The following is a description of a gene set: species: Mus musculus Mouse Gene Set: GOBP_RESPONSE_TO_AMINE Any process that results in a change in state or activity of a cell or an organism (in terms of movement, secretion, enzyme production, gene expression, etc.) as a result of an amine stimulus. An amine is a compound formally derived from ammonia by replacing one, two or three hydrogen atoms by hydrocarbyl groups., and this is the list of marker genes: Gnal, Myd88, Ppp1r9b, Nqo1, Drd1, Asic1, Slc1a1, Nr4a2, Ppp3ca, Pitx3, Itga2, Grin1 (glutamate receptor, ionotropic, NMDA1 (zeta 1)), Grin2a, Rgs9, Edn1, Rgs2, Ednra, Ppp1r1b, Gria1, Adra1b, Atp1a3, Cxcl2, Drd3, Jak2, Slc18a2, Adora2a, Drd5, Cps1, Gldc, Comt, Hnmt, Hprt1, Rps6kb1, Rgs10, Drd2, Cad, Trdmt1, Pde1b, Th, Oxtr, Adamts13, Drd4, Kcnc2, Cdk1, Rrm2b, Fosb (FBJ osteosarcoma oncogene B), Oxt, Hdac6, Ranbp2, Dbh, Uros, Kcnc1, Htr2b, Ass1, Nr4a1, Adipor2